The following is a description of a gene set: studied in species Homo sapiens Although transcriptional programs associated with T-cell specification and commitment have been described, the functional hierarchy and the roles of key regulators in structuring/ orchestrating these programs remain unclear. Activation of Notch signaling in uncommitted precursors by the thymic stroma initiates the T-cell differentiation program. One regulator first induced in these precursors is the DNA binding protein Tcf-1, a T-cell specific mediator of Wnt signaling. Yet the specific contribution of Tcf-1 to early T-cell development and the signals inducing it in these cells remain unclear. Here we assign functional significance to Tcf-1 as a gatekeeper of T-cell fate. We show that Tcf-1 is directly activated by Notch signals. Tcf-1 is required at the earliest phase of Tcell determination for progression beyond the early thymic progenitor (ETP) stage. The global expression profile of Tcf-1 deficient progenitors indicates that basic processes of DNA metabolism are downregulated in its absence and the blocked T-cell progenitors become abortive and die by apoptosis. Our data thus add an important functional relationship to the roadmap of T-cell development. We used microarrays to detail the global programme of gene expression of mouse ETP thymocyte after Ikaros inactivation with dominant negative of Ik at different stage. Genes down-regulated in comparison of TCF7 deficient early thymic progenitors versus the TCF7 sufficient ones. Human Gene Set: GSE33513_TCF7_KO_VS_HET_EARLY_THYMIC_PROGENITOR_DN from publication Germar K, Dose M, Konstantinou T, Zhang J, Wang H, Lobry C, Arnett KL, Blacklow SC, Aifantis I, Aster JC, Gounari F (PMID 22109558), and this is the list of marker genes: CD276, LRATD1, RGL1, GIMAP6, SLC2A1, SEC23A, C2CD3, MACROH2A1, PSME3IP1, NCAPD2, ARL14EP, APAF1, TFAP4, EPB41L4B, DLG4, SNN, AP5M1, TSN, SLC5A3, YPEL3, CHDH, FAM53C, GALNT16, DPH7, DSE, POLG2, METTL21A, INTS9, CD93, SPRED3, CSE1L, CFL2, CHL1, ATP13A2, FAM221A, PIGN, SNX9, EXOSC3, KRTAP2-4, PNRC1, LACC1 (NCBI Gene Id 144811), NPC1, COASY, NDUFA6, SLC30A4, DEDD, MRPS34 (mitochondrial ribosomal protein S34), LDHAL6B, MGA, AR, RPS18, EXOC7 (exocyst complex component 7), SYNC, DOCK7, ADGRL4, PPM1F, ZCCHC3, KIF7, EIF1B (eukaryotic translation initiation factor 1B), PAQR3, TRIM32, FRMD5, HELB, POLR2D, SNRPD2, ICA1, CD300LD, SF3B4, TPM2, NFYA, USP54, RNF157, INPP5F, SASS6, NET1, GPRC5B, SPATA1, KLHL35, MAD1L1, ACAD8 (NCBI Gene Id 27034), HOOK1, SIRT3, CDK16, HOXD9, VAPB, EIF2A, SMG1, RHOG, ABRACL, RNF220, TMEM108, ANAPC5, GLIS2, BLTP3A, CRYL1, NRROS, RPL26, PAOX (NCBI Gene Id 196743), ACVR2B, KLHDC10, LSM4, DNTT (DNA nucleotidylexotransferase), AQP7, SLC15A1, MRPL34, STX19, BRD9 (bromodomain containing 9), GAS2L3, HIF1A, FLT3, E2F2, OTULINL, BCR, GIMAP1, DMAC2L, AGPAT2, JUP, ATXN10 (NCBI Gene Id 9490), PHF2, GPR137B, GLOD4, ENO3, ROM1, HSD17B6, MRTFA, CACNA1D, SLC3A1, BCS1L, GRWD1, KLKB1, ATP11C, IKBKB, CPSF6, HS1BP3, PYCR2, GPR87, RERE, CORO1A, INTS3, ECI2 (enoyl-CoA delta isomerase 2), EFCAB11, BRDT, TSPAN2, PABPN1, PHPT1, DNA2, TCF7L2, ESR1, ZNF619, SGO1, TMEM267, PHOX2B, SMPD1, MELK, PIGM, SLC16A4, SUB1, TSPAN6, AP1G2, YEATS2, NR4A2, CCR9, LRRCC1 (NCBI Gene Id 85444), SKIC2, VSIG10, SUPT3H, ZDHHC15, POLR2G, PTBP1, IQSEC1, RPS26, ECHDC1, PPIH, IL12A, RPL14, MYL10, PLEK, ZC4H2, ABHD14A, TMX3, TPGS2, SLC25A27, TYW1, MBTD1, SSH1, ALCAM, BAZ1B, PSMD3, ZNF362, ADD3, CGGBP1, CASD1, TES (NCBI Gene Id 26136), GIPC1, MAST2, POLR1H, IFT80, CCL25, SCAP